The following is a description of a gene set: Polydactyly A congenital anomaly characterized by the presence of supernumerary fingers or toes. Human Gene Set: HP_POLYDACTYLY species: Homo sapiens, and this is the list of marker genes: ZFX, SETBP1, COG6, POU1F1, MMP23B, FOXA2, ARL3, CC2D2A, BBS5, HIRA, TRAF3IP1, CEP164, B9D2, BBS1, LHX4, TMEM218, LZTFL1, TCTN1, IFT74, CREBBP, AKT3, CEP120, DYNC2I1, ARMC9, PUF60, FANCD2, INPP5E, GJA8, FAM149B1, RERE, CILK1, HEATR3, NSD2, TXNDC15, CSPP1, TFAP2A, MEGF8, MKS1, GDF6, OTX2, SEMA3E, FLNA, GATA6, SALL1, SUFU, NPHP3, PTEN, AFF3 (NCBI Gene Id 3899), CPLANE1, TGFBR2, GABRD, SYNGAP1, HMGA2, HESX1, PDE6D, NKX2-6, CRB2, PDPN, PIK3R2, SKI, EFTUD2, ALMS1, TMEM216, COMT, BMP4, GJA5, TBX3, ARL6, NELFA, TRIM32, GJA1, PNPLA6, BBS7, CENPF, CFAP418, TTC21B, DDX59, SCLT1, BBS12, ZSWIM6, LHX3, IFT27, MBTPS2, GDF5, CCDC28B, IQCE, PLAA, EP300, WNT7A, TCTN3, RNU4ATAC, ALX3, UBE4B, ABCA12 (ATP binding cassette subfamily A member 12), BBS10, MYCN (MYCN proto-oncogene, bHLH transcription factor), EVC2, KIF3B, EBP, TWIST1, TCTN2, EFNB1, KCNAB2, NEK9, DACT1, GPC3 (NCBI Gene Id 6394), LMBR1, TMEM67, TMEM138, UQCC2, KIAA0825, KATNIP (NCBI Gene Id 23247), CIBAR1, GP1BB, EXTL3, AHI1, GLI1, PRKCZ, HSPG2, DHCR7, GLI2, LBR, FGFRL1, PRDM16, SETD5, KIAA0753, SUCLG1, MAP3K20, VPS35L, CPLX1, PITX1, CHSY1, CHST11, PHF8, KIAA0586, OTUD5, CNTNAP2, NKX2-5, IFT140, TMEM231, PRKACB, ZNF699, ZNF141, CHN1, PURA, SMOC1, WDR35, BMPR1B, NCAPG2 (non-SMC condensin II complex subunit G2), FBLN1, TMEM107, SCAPER, WASHC5, SCNM1, PRKACA, PPP2R1A, BBS4, CDC45, BLM, HNRNPK, TGFBR1, CDCA7, FANCB, ACOX1, PTCH1, CDKN1C, RREB1, RPGRIP1, KIF7, TASP1, OFD1, RAI1, CTU2, DPYSL5, CEP290, DYNC2H1, CASZ1, HYLS1, NEU1, DEAF1, INTU, MKKS, CD96, BHLHA9, EVC, CEP104, RAB34, TMEM237, RBM10, DYNLT2B, TFAP2B (NCBI Gene Id 7021), SEC24C, FGFR2, PLAG1, IFT52, PROP1, LUZP1, UFD1, RPGRIP1L, IFT57, GLI3, H19, H3-3B, LETM1, IFT172, COLEC10, WDR19, DYNC2I2, BBIP1, C2CD3, PIK3CA, IFT56, TOGARAM1, FLII, DYNC2LI1 (dynein cytoplasmic 2 light intermediate chain 1), SHH, SC5D, IFT43, MAX, HOXA13, TOPORS, TBX5, HOXD13, PIBF1, WDPCP, DYRK1A, CHD7 (chromodomain helicase DNA binding protein 7), IFT81, JMJD1C, GPC4, SPEN, CBY1, IGF2, BBS9, TTC8, CCDC22, RBBP8, FLI1, BBS2, RAB23, TMCO1, IFT80, HEPACAM, SALL4, PORCN, B9D1, MAPKAPK5, USP9X, SDCCAG8, PIGG, ZNF423, NEK1, IQSEC2, CEP19, ARVCF, ZIC3, CCND2, CEP41, MAFB, STAG2, INSR, CTBP1, ADNP, SMO, SPRED1, TBX1, NPHP1, ARL13B, SH2B1